The following is a description of a gene set: species: Homo sapiens Human Gene Set: KEGG_MEDICUS_REFERENCE_LESION_BYPASS_BY_TLS_AND_DSB_FORMATION Lesion bypass by TLS and DSB formation. Pathway ID: N01465. Pathway type: Reference. Pathway class: nt06508 Interstrand crosslink repair. Pathway Definition from KEGG: FANCD2+FANCI+Ub -> FAN1 == SLX+MUS81+EME1 == ERCC4+ERCC1+SNM1A -> REV1,REV3L,REV7, and this is the list of marker genes: SLX1B, REV3L, SLX4, EME1, DCLRE1A, MAD2L2, FAN1, SLX1A, FANCD2, ERCC4, MUS81, FANCI, ERCC1, REV1, UBB